The following is a description of a gene set: from publication Tabula Muris Consortium (PMID 32669714) Mouse Gene Set: TABULA_MURIS_SENIS_BRAIN_NON_MYELOID_OLIGODENDROCYTE_PRECURSOR_CELL_AGEING species: Mus musculus, and this is the list of marker genes: Dexi, Ccnd2, Dctn3, Chchd2, Nfkbib, Pgp (phosphoglycolate phosphatase), Eef1d, Lrp4, Bod1, Senp1, Sdc4, Ddah2, Echdc2, Grina, Rpl6, Ccdc80, Rac3, Psmc2, Usp22, Emc7, Rala, Smim30, Phpt1 (NCBI Gene Id 75454), Anapc11, Lxn, Fos, Kmt2b, Tnfrsf12a, Tceal9, Uchl1 (ubiquitin carboxy-terminal hydrolase L1), Unc119, Mrps18c, Tmem9 (transmembrane protein 9), Mdk, Prdx5, Trappc8, Mrpl28, Cltb, Map2k2, Snrpa, Mrps15, Tecr, Glrx2, Emc4, Pabpn1, Gnptg, Zftraf1, Spag7, Ndufb7, Swi5, Prxl2b (peroxiredoxin like 2B), Zfp580, Bcl7c, Rab3a, Arrb2, Pomp, Ubb (NCBI Gene Id 22187), Rpl13a, Mrps18b, Atg101, Lrrc8a, Phb1, Gng11, Ndufaf5, Reep2, Syngr1, S100a13, Mtarc2, Cryab, Slc25a39, Egr1, Fxyd7 (NCBI Gene Id 68670), Cygb, Tsc22d4, Psmb1, Selenom, Junb, Mettl5, Ssbp4, Mdh2, Ndufc2, Glis2, Rprm, Sox2, Bsg, Evi2a, Nicol1, Higd2a, Faim, H2-D1, Mrpl32, Ppp1r35, Pnrc1, Gsta4, Cdc26, Csf2ra, Tagln2, Kdm6b, Lamtor4, Nxt1, Rgcc, Sh3bgrl3, Ark2c, Rtn1, Cuta, Ptma, Trmt112, Ap2a1, Ubxn4, 6330403K07Rik, Psph, Jund, Fabp5, Ndufa8, Arhgdia, Selenok, A930003O13Rik, Ten1, Cdk2ap2, Med22, Snrpc, Fuz, Atp6v0b, Nudt16l1, Psmb6, Exosc7, Rabac1, Smim14, Nlgn2 (NCBI Gene Id 216856), Psmg3, Ppa1, Cyb5a, Dad1, Cfl1, Styx, Elfn1, Gm13889, Psmb7, Ak2, Ptgds, Ifi27, Arl8a, Acta2, Malat1, Trappc3, Cope, Zscan26, Prr13, Dctn6, Rogdi (NCBI Gene Id 98005), Spr, Apoe, Ccdc124, Sf3b2, Dstyk, Metrnl, C1qtnf2, H2-Eb1, Lmna, Tmed9 (NCBI Gene Id 67511), S100a1, Mien1, Wbp2, Gnb2, Stmn3, B2m, Fam89a (NCBI Gene Id 69627), Tpt1, Psma3, Brk1, Exosc9, Shisa4, Ppp1r11, Pgls, Dbndd2, Selenos, Drap1, Enho, Ube2e1, Vps29, Ubald1 (NCBI Gene Id 69005), Manbal, Mospd3, Lamtor1, Vps37d, Tmem160, Znhit1, Pianp, Nfkbia, Zfp428, Pfdn6, Pdlim7, Rtf1, Polr3gl, Ubb-ps, Atf3, Pfn1, Tmed10, Il17d, Ube2m, Ctsl, Metrn, Clstn3, Npm3, Tusc2 (tumor suppressor 2, mitochondrial calcium regulator), Ino80e, Rp9, Nherf1, Nnat, Mfge8, Msrb2, Tspo, Akt1s1, Cldn10, Tmem176b, Tmbim4, Rhoc, Laptm4a (NCBI Gene Id 17775), Gipc1, Ptn, Gng3, Chmp2a (charged multivesicular body protein 2A), Smco4 (single-pass membrane protein with coiled-coil domains 4), Praf2, Sv2a, Plvap, Rasl10b, Aamp, Ltbp3, Gstm1, Igfbp2, Tceal3, Glb1l, H2ax, Mrps18a, Bin1, Tomm6, Rab4b, Commd1, Btg2, Arpc3 (NCBI Gene Id 80396), Ptms, Lin37, Shisa5, Aup1, Sox3, Tpgs1, Lage3, Gpx4, Cd81 (NCBI Gene Id 12520), Psmd7, Rrp1, Fam241b, Sptan1, Smarcb1, Med10 (mediator complex subunit 10), Ubl7, Adrm1, Nbl1, Atf4, Sdf2l1, Ip6k2, Rnf126, Glt8d1, Acbd6, Ckap5, Atp6v0e, Ireb2, Vegfb, Dtx3, Ciao2a, Ambra1, Ramp1, Rbm26 (RNA binding motif protein 26), Sfxn5, Zfp503, Ranbp1, Dmac1, Samd4b, Zfp579, Erp29, Cnpy2, Atp5po, Mrps24, Bri3, Pcsk1n, Dynlrb1, Cebpzos, Aldoa, Rplp0, Mmp24os1, Tssc4, Psmb8, Csnk2b, Sdhc, Atp6v0c, Pnma8b, Ptpmt1, Ube2v1 (NCBI Gene Id 66589), Mea1, Ubxn1 (UBX domain protein 1), Gabarapl1 (GABA type A receptor associated protein like 1), Pllp, Polr2a, Srsf5, Rapgef1, Cystm1, Krt15, Plekhj1, H2bc27, Elof1 (NCBI Gene Id 66126), Tmed3, Cst3, Myo9b, Eif3f, Mycbp2, Gadd45a, Ankdd1b, Micu3, Trf, Frat1, Fkbp8, Ift27, Cotl1, Tubb2b, Fam181b, Ebna1bp2, Bud31, Nabp2, Ap2s1, Zfhx2, H2-K1, Rusc1, Adgrb1, Ap1s1, Ypel3, U2af1, Tbcb, Tmem100, Snw1, Ptges2, Phlda1, Per3, Tex261, Rheb, Reep4, Rpl13, Stub1, Ctnnbip1, Psma2, Fasn, Rab6b, Commd6, Jtb, Cacng4, Gnb1, Ppm1k, Pin1, Antkmt, Fth1, Calm2, Rnaset2b, Nav2, Fbxo2, Caly, Rnf5, Cd63, Krt14, Oaz1, Bloc1s2 (biogenesis of lysosomal organelles complex-1, subunit 2), Tmsb10, Ldhb, Ppib, Tspan7 (tetraspanin 7), Slc25a3, Fam43a, Sec11a, Ppp1r18, Nkx2-2, Pigyl, Etfb, Ly6h, Grb2, Sf3b4, Hexb, Rtl8c, Nat8f1, Gadd45gip1, Rpl7a, Ftl1, Mageh1, Tle5, Phldb1, Mrpl42, Cox5a, Lrrc4b, Eci1, Sat1, Tmub1, Arf1, Mfap5, Usf1, Trappc4, Atp6v1g1, Zfp414 (zinc finger protein 414), Tsc22d1, Gm14325, Adprh, Nudt3, Nrxn2, Dbi, Atp5mg, Ssna1, Sod1, Slc25a5, Gpx1, Eno1b, Cdc37, Map1lc3a, 0610010K14Rik, Scg5, Pcdhb9, Dynll2, Cuedc2, Tubb3, Selenow, 1110065P20Rik, Pdxk, Atp5mc2, Plpp3